The following is a description of a gene set: Human Gene Set: GSE29617_CTRL_VS_TIV_FLU_VACCINE_PBMC_2008_UP Genes up-regulated in comparison of peripheral blood mononuclear cells (PBMC) from TIV influenza vaccinee before vaccination versus that after the vaccination. Systems vaccinology has emerged as an interdisciplinary field that combines systems wide measurements and network and predictive modeling applied to vaccinology. Here we used the systems vaccinology approach to study the molecular mechanisms underlying th from publication Nakaya HI, Wrammert J, Lee EK, Racioppi L, Marie-Kunze S, Haining WN, Means AR, Kasturi SP, Khan N, Li GM, McCausland M, Kanchan V, Kokko KE, Li S, Elbein R, Mehta AK, Aderem A, Subbarao K, Ahmed R, Pulendran B (PMID 21743478) species: Homo sapiens, and this is the list of marker genes: RNF212B, PDE4B, TMOD1, GPR183, ARG1, ZC3H10, RBM7, STPG3-AS1, LRRC31, CCDC71L, CCDC198, KBTBD2, CXCL10, DNAH6, OTUD1, CREBRF, ZNF326, DNAJB9, TIPARP, SRSF4, MAFK, CXCL8, SNHG15, YPEL5, MIR23AHG, ZFP36, LINC01300, GZF1, PIM3, RAB18, SIAH1, USP42, UBXN7, DHX15 (NCBI Gene Id 1665), RGS2, MED21, ZFP36L1, ELF4, NDEL1, TLCD1, N4BP3, RASGEF1B, IP6K2, ZBTB21, USP36, STK32B, ZNF234, CNTNAP3B, KLHL15, PARGP1, ZNHIT3, ATF3, EML4, RELT, BRAF (NCBI Gene Id 673), CTNNB1, COQ10B, GPC4, RANGAP1, ZBTB5, NR4A3, NR4A1, FOS, MMP25, LIF, GNE (glucosamine (UDP-N-acetyl)-2-epimerase/N-acetylmannosamine kinase), CHORDC1, GASK1A, LONRF2, USP3, BHLHE40, NPY2R, ATG2A, OBP2B (odorant binding protein 2B), L3MBTL3, TUFT1 (NCBI Gene Id 7286), BEND6, BCL3, EXOC8, RGS1, JARID2 (jumonji and AT-rich interaction domain containing 2), SAP130, DYNC1LI2, SERPINB2, BCLAF1, CHRNA9, EBLN2, SAMD8, FOSL2, WHAMM, ST8SIA3, MED26, LAMP3, IVNS1ABP, KLK10, HBEGF, YTHDC1, LDB2, CYP4F3, ITPRIP, TM2D3, ANXA3, BMAL1, HIF1A, EBF3 (EBF transcription factor 3), COLGALT2, CSRNP1, NGRN, RAD21-AS1, LINC01257, TLE3, PSMD12, ZBTB46, SNRK (SNF related kinase), ZNF709, FAM201A, SDE2, TSC22D2, KLHL29, RFPL1, ZC3H12A, ADAM5, KAT7, SREK1, SMIM22, DHCR7, MEF2D, PLBD2, TASOR2, TRIM7, LINC00205, NUAK1, CXCR4, FEM1C, SAMD4B, ZNF236 (zinc finger protein 236), SIK1, LINC01904, CFAP20, RAB1A, ARID5A, DCP1A, ZNF92, ETV3, ETF1, ZFP28, SLIT2, PI3, LIPG, FOXD1, CBX2, C20orf203, SLC9A7, CCNL1, G0S2, PLK3, JUND, DDX24, LOH12CR2, REL, CD69 (CD69 molecule), CYTIP, PLK2, NFE2L2, NAMPT, ZFYVE27, OSM, MARCHF6, PRSS33, ARMC12, NECAP1, NR2E3, PHF3, BTG2, PTBP2, SMNDC1, SKIDA1, IST1, AKAP8, CCL20, PTP4A1, PPTC7, PARD6B, SNX29P2, TENT4A, GOLGA4, PLCL1, RICTOR, ICOS, JMJD1C, JUNB